Given this list of marker genes DAP3, LINC00518, SUPT20H, ALG13, BICDL1, BABAM1, SAXO2, COPE, ALG8, TMA16, NOCT, CFAP410, EID1, DRD4, CMAHP, ANXA2P2, DDX51, CAMSAP1, ATF7IP2, AKAP12, DGKK, FBXW2, COL8A2, AKT2, CASP4, AMIGO2, AMER2, CPXM1, APOD, DNAH9, ALDH16A1, FARP1, CYP4F3, CORO1A, AKT1S1, FAM89B, ATF1, ADAMTS17, CNGA2, AMDHD1 (NCBI Gene Id 144193), AMACR, CSGALNACT1, ATP13A2, APOL5, CLXN, CCND3, COL9A2, CDO1, DVL2, DNAJC22, CCDC42, EPB41L5, ARL6, EOGT, C1S, DDX5, DUT, CKS1BP6, DNAJC1, BOLA3, INSYN2A, DHRS7B, EVC2, ATP7A, AKR1C8, UTP25, CAMK2A, EOLA2, ZFAND4, CALML6, MINDY2, ARMCX1, CDC25A, CSPP1, BNIP2, APOC1, RIPPLY3, COTL1, ELOVL1, EGR2, TEKTIP1, DEFA6, FDXR, ARID5A, ZFHX3, FEZ2, SDHAF3, DPP3, COQ4, CCNB2, INIP, EPB41L2, EMILIN1, CTCFL, BYSL, ATG14, EFHD1, FOXC1, FER1L5, MYRFL, AMZ2P1, ANKK1, MIX23, ALKBH8, DNAJC27, TMEM255A, CDKN1C, ARHGAP31, CTSF, DDX25, ANGPT4, C11orf42, APCDD1, DLC1, DPT, DNAJB2, CLEC4F, BRIP1, CCDC178, CTSO (NCBI Gene Id 1519), BAG2, ARL13B, CCDC61, ARL4A, ADARB1, ACRV1, CSTL1, DNAJB11, COX16, PRR33, FOXE1, CIRBP, ANP32A, CTLA4, CBFA2T3, C1QL4, PSME3IP1, DLEC1, ENOX2, C9orf40, ATP5PF, ATP10A (ATPase phospholipid transporting 10A (putative)), CABCOCO1, BMP5, DDX31, BTNL9, CDC14C, BLOC1S1, CASS4, ARMC7, ATG3, EPC2, ELOVL3, CREB3L1, FGF12, ARV1, CLIC3, CCDC86 (coiled-coil domain containing 86), FDCSP, CDHR5, AMZ2, CD79B, NELFB, SPATA6L, ABHD17A, CTSS, CD200R1, AMD1, DAB1, BTG2, ADCY10, FECH, CELSR1, CBX8, CYP1B1, ASAP3, CTSD, ATP6V1F, RHEX, ERGIC1, CDH12, FA2H, ETV5, DSCR8, ATIC, COX7C, CST1, BOD1, KNOP1, DNAJC5B, MCEMP1, IFTAP, BCAS3, C1R, CASP7, EDA, DGCR2, here is a description of the gene set: T cells develop from progenitors that migrate from the bone marrow into the thymus. Thymocytes are subdivided roughly as being double negative (DN), double positive (DP), or single positive (SP), based on the expression of the CD4 and CD8 coreceptors. The DN stage is heterogeneous and can be subdivided into four distinct subsets in mice based on the expression of CD44 and CD25. In human, three distinct DN stages can be recognized: a CD34+CD38−CD1a− stage that represents the most immature thymic subset and the consecutive CD34+CD38+CD1a− and CD34+CD38+CD1a+ stages. Human DN thymocytes mature via an immature single positive (ISP CD4+) and a DP stage into CD4+ or CD8+ SP T cells that express functional T cell receptors (TCR) and that exit the thymus. In this study, gene expression was measured in each of these nine stages. from publication Dik WA, Pike-Overzet K, Weerkamp F, de Ridder D, de Haas EF, Baert MR, van der Spek P, Koster EE, Reinders MJ, van Dongen JJ, Langerak AW, Staal FJ (PMID 15928199) Genes down-regulated in double negative thymocyte versus immature CD4 single positive cells. Human Gene Set: GSE22601_DOUBLE_NEGATIVE_VS_IMMATURE_CD4_SP_THYMOCYTE_DN studied in species Homo sapiens